The following is a description of a gene set: species: Mus musculus Mouse Gene Set: GOBP_MOLTING_CYCLE The periodic casting off and regeneration of an outer covering of cuticle, feathers, hair, horns, skin, etc., and this is the list of marker genes: Cdh3, Sos1, Fermt1, Bcl2, Psen2, Rbpj, Trps1, Lgr4, Tert, Gsdma3, Foxi3, Nfatc1, Mfsd12, Lncpint, Wnt5a, Sav1, Dlx3, Mreg, Eda, Gnas, Smad4, Sox9, Ctsl, Egfr, Edar, Fuz, Nf1, Hdac1, Ctnnb1, Mysm1, Barx2, Hoxc13, Intu, Krt17, Fgf7, Igfbp5, Apc, Ercc2, Notch1 (notch 1), Rela, Fzd3, Lgr5, Lrp4, Inhba, Krt28, Alx4, Fzd6, Akt1, Krt16 (keratin 16), Pias4, Ptgs2, Pkp3, Myo5a, Cd109, Tradd (NCBI Gene Id 71609), Sox21, Col6a1, Foxn1, Prss8, Wnt10a, Wnt10b, Krt14, Foxe1, Pdgfa, Krtap21-1, Lhx2, Mpzl3, Nsdhl, Naglu, Dkk4, Msx2, Sostdc1, Pum2, Dsg4, Hdac2, Ext1, Hpse, Ldb2, Trpv3, Fgfr2, Snai1, Fa2h, Dnase1l2, Atp7a, Dbi, Tmem79, Dkk1, Tnfrsf19, Runx3, Krt25, Apcdd1, Nipbl, Gli2, Ppard, Gorab, Gal, Krtap4-8, Dsc1, Dicer1, Tnf, Pla2g10, Shh, Trpc4ap, Krtap4-9, Krtap6-2, Lamc1, Gprc5d (NCBI Gene Id 93746), Ngfr, Lama5, Farp2, Ldb1, Ptch2, Runx1, Tspear, Celsr1, Sox18, Tfap2c, Eps8l3, Psen1, Vangl2, Nsun2 (NCBI Gene Id 28114), Trpv1, Lrig1, Norad, Nom1, Trp63, Bmal1, Numa1, Fgf10, Zdhhc21, Clock, Krt71, Krt27, Acvr1b, Krtap4-26 (keratin associated protein 4-26), Zmpste24, Foxq1, Fst, Edaradd, Per1, Tsku, Ppp1r13l, Tgfb2, Smo